Given this list of marker genes IRF4, CTLA4, IFNGR1, IL12A, STAT4, IL12A-AS1, FCGR2A, CCR1, DNASE1, PTPN22, HLA-DPB1, C4A, HLA-DPA1, UBAC2, PRTN3, HLA-B, TLR4 (toll like receptor 4), MEFV, FCGR2B, TREX1, ERAP1, FAS, NOD2, IL10, PRG4, TNFRSF1A, KLRC4, IL23R, here is a description of the gene set: Pleuritis studied in species Homo sapiens Human Gene Set: HP_PLEURITIS Inflammation of the pleura.